Given this list of marker genes ERGIC1, HADHB, COL25A1, PMP22, SCYL2, TBC1D24, FARS2, HADHA, ATP6V1B2, VPS13A, LMX1B, SLC26A2, ERCC6, here is a description of the gene set: Human Gene Set: HP_EQUINOVARUS_DEFORMITY studied in species Homo sapiens Equinovarus deformity